The following is a description of a gene set: The chemical reactions and pathways resulting in the formation of purine nucleoside monophosphate, a compound consisting of a purine base linked to a ribose or deoxyribose sugar esterified with phosphate on the sugar. studied in species Mus musculus Mouse Gene Set: GOBP_PURINE_NUCLEOSIDE_MONOPHOSPHATE_BIOSYNTHETIC_PROCESS, and this is the list of marker genes: Ada (adenosine deaminase), Impdh1, Prps2, Gmps, Pnp, Impdh2, Adk, Ampd3, Ampd1, Gmpr2, Atic, Ampd2, Gmpr (NCBI Gene Id 66355), Paics, Gart, Ppat, Aprt, Dguok, Adsl, Dck, Adss2, Pfas (phosphoribosylformylglycinamidine synthase (FGAR amidotransferase)), Adss1, Nudt2, Hprt1